Given this list of marker genes COL6A3, MRAS, CXCL10, ITGB1BP2, MYBPC1, BIN1, TNNT3, MYL11, CRYAB, TNNI2, SYNGR2, ABLIM3, PDLIM5, TNNI1, LDB3, BCAN, MYH1 (myosin heavy chain 1), TNNC1, CTF1, DES, CASQ2, MTSS1, TNNC2, MYH8, SGCD, FHL1, UTRN, MYL6B, MACF1, MYBPC2, MEF2C, ACTA2, MYH3, TPM1, MYBPH, MYL4, SGCG, NEBL, MYO10, AEBP1, MEF2D, MYOM1, TAGLN (NCBI Gene Id 6876), BORCS8, MYL1, HBEGF, PALMD, SMPX, here is a description of the gene set: Muscle development genes up-regulated in Rh4 cells (alveolar rhabdomyosarcoma, ARMS) but not in the RD cells (embryonal rhabdomyosarcoma, ERMS) after knockdown of PAX3-FOXO1 fusion by RNAi for 72 hr. The chromosomal translocation t(2;13), characteristic for the aggressive childhood cancer alveolar rhabdomyosarcoma (aRMS), generates the chimeric transcription factor PAX3/FKHR with a well known oncogenic role. However, the molecular mechanisms mediating essential pathophysiological functions remain poorly defined. Here, we used comparative expression profiling of PAX3/FKHR silencing in vitro and PAX3/FKHR-specific gene signatures in vivo to identify physiologically important target genes. Hereby, 51 activated genes, both novel and known, were identified. We also found repression of skeletal muscle-specific genes suggesting that PAX3/FKHR blocks further differentiation of aRMS cells. Importantly, TFAP2B was validated as direct target gene mediating the anti-apoptotic function of PAX3/FKHR. Hence, we developed a pathophysiologically relevant transcriptional profile of PAX3/FKHR and identified a critical target gene for aRMS development. species: Homo sapiens from publication Ebauer M, Wachtel M, Niggli FK, Schäfer BW (PMID 17525748) Human Gene Set: EBAUER_MYOGENIC_TARGETS_OF_PAX3_FOXO1_FUSION